The following is a description of a gene set: Genes down-regulated in CD8 T cells: KLRB1 int versus KLRB1-. from publication Walker LJ, Kang YH, Smith MO, Tharmalingham H, Ramamurthy N, Fleming VM, Sahgal N, Leslie A, Oo Y, Geremia A, Scriba TJ, Hanekom WA, Lauer GM, Lantz O, Adams DH, Powrie F, Barnes E, Klenerman P (PMID 22086415) We used microarray to compare gene expression between CD161++/CD161+/CD161-CD8+ T cells from human cord blood. species: Homo sapiens Human Gene Set: GSE33424_CD161_INT_VS_NEG_CD8_TCELL_DN, and this is the list of marker genes: FAAP20, LPP-AS2, ZCCHC24, NATD1, CD151, ITGB7 (integrin subunit beta 7), C17orf58, CACNG7, ANKRD33B (NCBI Gene Id 651746), RAP2A, KIZ, GPR155, SYTL4, SNAP29, CTSH, ANKRD37, DDX19B, ATP5IF1, XKRX, SLC38A1, CUL3, SORD, UGGT1, ATG9A, RHOA, POFUT1, CNPY4, MMGT1, GRK4, CCDC157, CRIPT, FAM43A, CD209, CDC42SE1, CADM1, SLC38A10, ANKH, WDR90, MTPN, FRG1, KLC2, KCNJ6, RHOBTB1, NDUFB11, HDAC11, NDRG1, NEK3, LRRC8C, MAN1C1, DUSP3, RPL9, SLAMF1, NLRC3, KBTBD11, RDH12, TFDP2, ZMAT3, PRKAG2, TCP11L2, ANXA1 (annexin A1), SH3PXD2A, DONSON, GPN3, PISD, KLHDC1, ATRNL1, SLC44A1 (NCBI Gene Id 63942), NUCB2, OAZ2 (NCBI Gene Id 4947), SLC49A4, CNKSR3, UBE2E3, CENPA (centromere protein A), UNC5CL, ALCAM (NCBI Gene Id 214), SNX12, RFC1, PADI2, AMPD3, LGALSL, IKBIP, GUCD1, SLC35D2, RND3, RFLNB, CAMTA1, MADD, NEDD4, COX6A2, PRMT2, MTURN, STAU2, UBASH3B, CMAS, FUT11, ARHGAP18, THRA, MAGEE1 (MAGE family member E1), AGL, GRIA3, TXNDC5, MMP11, URM1, TUBA1A, PRSS12, ERI2, HELB, TTYH3, PFN2, COX7A2L, FAHD2A, SRP14, CELA3B, INPP5A, SEC22C, SYT4, UQCC3, MPRIP, SELENOP, NID1, FGR, CHRNB1, GSN, MBD1, WDFY2, SIKE1, S100A1, LY96, RAB31, IGSF8, SLC66A2, GKAP1, MKRN1, AP3D1, TMEM107, CRTAP, GCSAM, CNTD1, AFMID, CRELD2, GABARAPL1, STK24, DDB2, HES6, ITGA10, ELAC1, VMAC, ZW10, PXDC1, ENTPD4, RWDD3, PDE2A (NCBI Gene Id 5138), EEF2K, LIFR, CPM, PTTG1IP, ENTPD5, DLG4, FMO5, PITPNC1, FYN, KLHL14, ADD3, CYP27A1, ZNF395, RASSF4, ANXA5, TPRG1L, RAB11FIP5 (NCBI Gene Id 26056), DYNC1I2, UFC1, ZNF274, TTL, ZNF862, CRYBG3, CNST, DUSP22, CDC25B, E2F2, ARFGEF3, ABCA3, PTGER4, H2AX, MICAL1, CDC42BPG, UPB1, FAM8A1, VAT1, CSRP2, CNPPD1, ARMC3, TSC22D1, RUNX2, TAX1BP3, CD99L2, PHC1 (NCBI Gene Id 283368), DIRAS2 (NCBI Gene Id 54769), KLHDC10, SPNS2, WDR81